Given this list of marker genes CASK, BBS2, MOSMO, TXNDC15, RAB8A, BBIP1, DRD2, TTC8, GUCY2D (guanylate cyclase 2D, retinal), BBS7, UMOD, EFCAB7, PKD2L1, TAS2R46, GNAT1, SHANK2, MCHR1, SNAP29, IQCE, PDE6G, SCNN1A, PRCD (NCBI Gene Id 768206), CNGB1, EVC, TAS2R43, ARL13B, GPR37L1, EVC2, PROM1, PKD2, ARL13A, CNGA1, BBS1, PKD1L1, RHO, PROM2, PDE6H, FFAR4, TAS2R4, ROM1, HHIP, TCTN3, TMEM231, GPR157, SEPTIN2, DHRS3, SHANK3, CNGA4, PDE6A, GNAT2 (G protein subunit alpha transducin 2), CYS1, ADCY3, CLTB, CDHR1, BBS5, BBS9, EHD1, BBS4, TMEM67, MICALL1 (NCBI Gene Id 85377), DRD1, PHLPP2, TMEM17, PKD1, TCTN2, SMO, GPI, TSPEAR, BRWD1, PDE6B (NCBI Gene Id 5158), EHD3, GPR161, PTCH1, CNGA2, MXRA8, SSTR3, DRD5, NAPEPLD, EPS15, GPR88, here is a description of the gene set: The portion of the plasma membrane surrounding a cilium. species: Homo sapiens Human Gene Set: GOCC_CILIARY_MEMBRANE